The following is a description of a gene set: from publication Yevshin I, Sharipov R, Kolmykov S, Kondrakhin Y, Kolpakov F (PMID 30445619) Mouse Gene Set: ZFP58_TARGET_GENES species: Mus musculus, and this is the list of marker genes: Mir6352, Inpp5f, Gm11266, Gm22888, Zc3hav1, Zmiz1, Tbl2, Yeats2, Lhx6, Cfap36 (cilia and flagella associated protein 36), Gorab, Cd46, Srsf4, Rab11bos1, Polrmt, Ttc6, Col8a2 (collagen, type VIII, alpha 2), Pard3 (NCBI Gene Id 93742), Redic1, Rnaseh2a, Blvra, Tcn2, Ywhaq, Gm15239, Clec12a (NCBI Gene Id 232413), Abcf3, Cbfb, Thbd, Cnih4, Bora, Aff4, Arfip1, Scmh1, Spindoc, Calcrl, Fam98c, Prkar1a, Ank3, Zbtb44, Pdlim3, Tdrd9, Polr3k, Ccnc, Slc25a25, Adipor2, Lpcat1 (NCBI Gene Id 97903), Tdp2, Cxadr, Gm23779, Asnsd1, Psmd5, Rev1, Smyd3, C430039J16Rik, Cnksr3, Hmox1, Fgfr1, Fahd2a, Tbce, Bcl7c, Borcs5, Foxc2, Ska1, Trpm1, Fxr1, Mzt1, Topbp1, Lmbr1l, 4933425M03Rik, Glt28d2, Ehbp1, Mir5618, Zfp760, Gm4419 (predicted gene 4419), Ifrd2, Mtfr1, Qdpr, Chrdl1, Ndufv1, Rock1, Gtdc1, Igfbp5, Gclm, Nbeal1, Pdzd11, Nvl (NCBI Gene Id 67459), Hsd17b11, Nek2, Accs, Celrr